Given this list of marker genes NKX2-1, PRKG1, GHRHR, THRAP3, NLGN1, RORC, KAT5 (NCBI Gene Id 10524), RORA, BMAL1, ADORA2A, BMAL2, MTNR1B, CLOCK, NPS, BTRC, GHRL, CRH, NPY2R (NCBI Gene Id 4887), GHRH, FBXW11, here is a description of the gene set: studied in species Homo sapiens Any process that activates or increases the frequency, rate or extent of a circadian rhythm behavior. Human Gene Set: GOBP_POSITIVE_REGULATION_OF_CIRCADIAN_RHYTHM